Given this list of marker genes MBTPS2, PTPN22, UROD, UROS, GATA1, CTLA4, PRTN3, HLA-DPB1 (NCBI Gene Id 3115), HLA-DPA1, here is a description of the gene set: Inflammation of the sclera. studied in species Homo sapiens Human Gene Set: HP_SCLERITIS Scleritis